The following is a description of a gene set: Mouse Gene Set: chr11B2 species: Mus musculus, and this is the list of marker genes: B9d1os, Pigl, Zfp286os, A530017D24Rik, Tnfrsf13b, Adora2b, Wsb2-ps, Gm12268, Fbxw10, B9d1, Tmem11, Myo15a, Fam83g, 4930412M03Rik, Map2k3os, Epn2, Shmt1, Aldh3a2, Ulk2, Mief2, Gm12279, Drc3, Mmgt2, Gid4, Gm12616 (NCBI Gene Id 102638994), Slc47a2, Drg2, Srebf1, Gm12269, Gm12625, Gm12619, Atpaf2, Gm12626, Zswim7, Ncor1, Snord49b, Gm12267, Snord65, Mir6922, Gm12612, Kcnj12, 2410006H16Rik, Aldh3a1, Gm12274, Trpv2, Gm12617 (predicted gene 12617), Gm12271, Gm12628, Usp22, Gm12624, Gm12622, Gm12280, Alkbh5, Ubb, Tvp23b, Akap10, Dhrs7b, Llgl1, Gm12611, Lrrc75aos1, Gm12275, Gm12273, Gm12266, Gm12623, Gm24151, Cenpv, Gm12613, Gm12618, Rps13-ps5, Gm12621, Slc5a10, Gm12627, Map2k3, Grap, Mir5100, Gm12615, Natd1, Slc47a1, Mfap4, Prpsap2, Lrrc75aos2, Gm12614, Specc1, Smcr8, Gm12620, Lrrc75a, Ttc19, Mapk7 (mitogen-activated protein kinase 7), Gm23341, Snord49a, Mir6921, Trim16, Rnf112, Flii, Zfp287, Zfp286, Tom1l2, Top3a